The following is a description of a gene set: Human Gene Set: GOBP_CORTISOL_BIOSYNTHETIC_PROCESS studied in species Homo sapiens The chemical reactions and pathways resulting in the formation of cortisol, the steroid hormone 11-beta-17,21-trihydroxypregn-4-ene-3,20-dione. Cortisol is synthesized from cholesterol in the adrenal gland and controls carbohydrate, fat and protein metabolism and has anti-inflammatory properties., and this is the list of marker genes: DKK3, BMP2, DGKQ, CACNA1H, REST, CYP11B2, WNT4, CYP11B1, BMP5, H6PD